The following is a description of a gene set: species: Homo sapiens Human Gene Set: REACTOME_GLUTATHIONE_SYNTHESIS_AND_RECYCLING Glutathione synthesis and recycling, and this is the list of marker genes: GGT5, GGT7, GGT1, CNDP2 (NCBI Gene Id 55748), CHAC2, GGT6, CHAC1, GSS, GCLC, GGCT, OPLAH, GCLM